Given this list of marker genes H2-M3, Cd3e, Fadd (Fas associated via death domain), Tlr3, Cd276, Klre1, Tlr4, Abl2, Slc11a1, Tlr9, Runx1, Carmil2, Slc7a5, Cyrib, Cd2, Nras, Cd226, Wnt5a, Il1b, Il12rb2, Il23r, Hspd1, Tlr8, Trim27 (tripartite motif-containing 27), Clec7a, Pde4b, Fzd5, Cebpg, Lta (NCBI Gene Id 16992), Ccr2, H2-Q7, Il12rb1, Hras, Arid5a, Havcr2, Rasgrp1, Ulbp1, Il12a, Il12b, Raet1d, Tlr7, App, Slamf6, Jak2, Il2, Tnfrsf13c, Il27 (interleukin 27), Cd160, Ripk2, Zp3, Klrk1, Bcl3, Cd14, Ifnar1, Scrib, Sash3, Isg15, Il18r1, Cd244a, F2rl1, Cd27, Isl1, Cd1d1, Il21, Pde4d, Il27ra, Zfpm1, Tnfsf4, Txk, Irf8, Tyk2, Mir21a, Ptpn22, Mir155, Il18, Crtam, Slamf1, Ticam2, Tnfsf9, Flt3, Il1r1, Tnf, Abl1, Cd40lg, Pycard, Il23a, here is a description of the gene set: studied in species Mus musculus Mouse Gene Set: GOBP_POSITIVE_REGULATION_OF_TYPE_II_INTERFERON_PRODUCTION Any process that activates or increases the frequency, rate, or extent of interferon-gamma production. Interferon-gamma is also known as type II interferon.